Given this list of marker genes ALDH7A1, PLPBP, ALPI, PIGV, PNPO, ALPL, PDXK, here is a description of the gene set: Human Gene Set: WP_VITAMIN_B6DEPENDENT_AND_RESPONSIVE_DISORDERS studied in species Homo sapiens Vitamin B6-dependent and responsive disorders